The following is a description of a gene set: part of: SLC-mediated transport of inorganic anions studied in species Homo sapiens Reactome Pathway: Sodium-coupled phosphate cotransporters Phosphorus is an essential element that is critical for structural and metabolic roles in all living organisms. Cells obtain phosphorus in the form of negatively-charged inorganic phosphate (Pi). Two SLC families transport phosphate in mammals; SLC34 (Murer H et al, 2004) and SLC20 (Collins JF et al, 2004). Both are secondary-active, Na+-coupled transporter systems which use the inward Na+ gradient (from the Na+-K+-ATPase) to drive phosphate influx into cells (Virkki LV et al, 2007)., and this is the list of marker genes: SLC17A1, SLC34A3, SLC20A1, SLC20A2, SLC34A1, SLC34A2